The following is a description of a gene set: Genes having at least one occurence of the motif CAGCAGG in their 3' untranslated region. The motif represents putative target (that is, seed match) of human mature miRNA hsa-miR-370 (v7.1 miRBase). Human Gene Set: CAGCAGG_MIR370 studied in species Homo sapiens, and this is the list of marker genes: BRCA1, DHX57, DCLRE1B (NCBI Gene Id 64858), FBRS, LIN28A, TRIT1, HNRNPAB, HDAC4, ASB15, SNF8, HPS1, MUC4, IQSEC2, FRK, PARP6, MAP3K8, DUSP3, ARID4B, TMEM127, ZDHHC5, RGS3, SOX12, BEST3, DDX3X, KLC2, PLCG1, KLF12, CFL1, TRAIP, IFFO1, SMG7 (SMG7 nonsense mediated mRNA decay factor), CIT, ARCN1, DND1, CACNG1, PRDM10, NCDN, GRIN3A, NFATC3, SENP5, FBXW5, CEP112, ABR, TMEM266, SRSF11, NFASC, SMARCD1, TAOK1, MTSS1, ZC3H7B, GABBR1, TRIM44, BAAT, MINDY4, CLUH, CD164L2, PKNOX2, NLGN2, FAM76B, KMT2A, AQP4, ANK3, ABCB9, SLC38A3, ACACA, SLC4A4 (solute carrier family 4 member 4), ZC3H12B, CHRD, USP6, PHF20L1, PPM1B, ZNF587, TRIM33, ZMYND11, CDK16, MTUS1, FOSB, CCL21, NAA40, GOLGA2P7 (GOLGA2 pseudogene 7), INO80, HERC4, ZBTB39, FGF7P3, WDR26, SPEF1, ING3 (NCBI Gene Id 54556), PCNX2, FBXO24, ILF3, BAZ2A, CCNJ, DDX3Y, HSPA14, STAT3, ARF1, CNTNAP1, NAA15, YAF2, ATG14, TMEM47, CAVIN1, PPIL2, PHF20, CCDC85B, ILRUN, TPM4, SLAMF6, ORC5, PBRM1, PSD2, OGT, RAB3IP, ADPRM, RAP1GDS1, MAP2K7, NCALD, ZC2HC1C, MARCKS, E2F3, STX1B, VSTM2L, CDC42SE1, JAZF1, SPTSSB, CCNK, FOXP4, USP37, NSUN4, DMRTB1, MED29, CHST3, TGFBR2, XKR4, DNMT3B, PDCD11, CLCA3P, CTBP2, SPRYD3, FGF7, DNMT3A, SERTAD4, DCDC1 (doublecortin domain containing 1), UBAP2, DSCAM, VDAC2, ATXN1, CASK, KIFC2, TAP2, CTIF, P4HA1, MAPRE1, ST3GAL3, PCDH10